Given this list of marker genes SHMT2, SHMT1, ALDH1L2 (NCBI Gene Id 160428), MTHFD1, DHFR2, MTHFD1L, SLC19A1, SLC46A1, FOLR2, MTHFR, FPGS, DHFR, MTHFS, SLC25A32, ALDH1L1, MTHFD2, MTHFD2L, here is a description of the gene set: studied in species Homo sapiens Metabolism of folate and pterines Human Gene Set: REACTOME_METABOLISM_OF_FOLATE_AND_PTERINES